The following is a description of a gene set: species: Homo sapiens Abnormal venous morphology An anomaly of vein. Human Gene Set: HP_ABNORMAL_VENOUS_MORPHOLOGY, and this is the list of marker genes: SMOC1, GJC2, NCAPG2, AGPAT2, TGFB2, GBA1, AEBP1, NME5, TEK, EPHB4, MCIDAS, KIF5A, DNAAF5, TBX5, ANTXR1, RBM10, HIRA, CIROP, PRKCD, GNB2, PROS1, UQCRFS1 (ubiquinol-cytochrome c reductase, Rieske iron-sulfur polypeptide 1), FOS, ODAD4, CWC27, NEK10, C1R, PRKACB, RSPH4A, SPEF2, THBS2 (thrombospondin 2), DNAJB13, LEMD2, JMJD1C, PIK3R1, ZNF699, POLR3A, BANF1, PPP1R15B, NOTCH3, FOXJ1, BAP1, CAVIN1, ERCC8, PDCD10, ATP6V1E1, FADD (Fas associated via death domain), FOXC2, GP1BB, BSCL2, CFAP74, RSPH3, AKT1, LMNA, ENG, RPGR, PIK3CA, ODAD3 (NCBI Gene Id 115948), PDGFRB, SLC39A13, GLMN, ARVCF, MMP21, OFD1, CCNO, LRRC56, NME8, CFAP298, SEMA4D, C1S, SLC12A3, PTEN, CREBBP, MSX2, LRPPRC, CCDC39, SMAD3, EP300, COMT, ZMYND10, KRIT1 (KRIT1 ankyrin repeat containing), ZIC3, ADH5, ANGPT2, FOXF1, PIEZO1 (NCBI Gene Id 9780), MID1, COL3A1, VEGFC (NCBI Gene Id 7424), PLXND1, SMG8, UBE2A, SRCAP, ZMPSTE24, DNAH11, ACVR2B, FLT4, ATP7A, GAS2L2, DNAL1, CLCNKB (NCBI Gene Id 1188), PLOD1, RASA1 (NCBI Gene Id 5921), SEC24C (NCBI Gene Id 9632), TTC12, UFD1, GPR35, RREB1, CLXN, DRC1, CFC1, TCF4, CFAP300, CCDC40, SLC29A3, DNAH5, HYDIN, SPAG1, FANCB, DNAAF11, ODAD2, DNAH9, ATN1, WT1, DNAAF1, ATP6V0A2, VHL, NDP, GNAQ, TMEM260, STK36, DNAAF4, G6PC3, CAV1, PTDSS1, DNAAF3, RAI1, COG4, AGGF1, CCM2, ATP6V1A, NKX2-6, CFAP221, DNAH1, MED25, MST1, DNAI2, RSPH1, DNAI1, SMAD2, DNAAF2, RSPH9, FIBP, PROC, PYCR1, PPARG, TBX1, ODAD1, DNAAF6, KDM3B, ALX4, SLC25A24